The following is a description of a gene set: Human Gene Set: HUANG_GATA2_TARGETS_UP Genes up-regulated in G1ME cells (megakaryocyte/erythroid progenitor lacking GATA1) upon knockdown of GATA2 by RNAi. from publication Huang Z, Dore LC, Li Z, Orkin SH, Feng G, Lin S, Crispino JD (PMID 19620289) GATA-2 is an essential transcription factor that regulates multiple aspects of hematopoiesis. Dysregulation of GATA-2 is a hallmark of acute megakaryoblastic leukemia in children with Down syndrome, a malignancy that is defined by the combination of trisomy 21 and a GATA1 mutation. Here, we show that GATA-2 is required for normal megakaryocyte development as well as aberrant megakaryopoiesis in Gata1 mutant cells. Furthermore, we demonstrate that GATA-2 indirectly controls cell cycle progression in GATA-1-deficient megakaryocytes. Genome-wide microarray analysis and chromatin immunoprecipitation studies revealed that GATA-2 regulates a wide set of genes, including cell cycle regulators and megakaryocyte-specific genes. Surprisingly, GATA-2 also negatively regulates the expression of crucial myeloid transcription factors, such as Sfpi1 and Cebpa. In the absence of GATA-1, GATA-2 prevents induction of a latent myeloid gene expression program. Thus, GATA-2 contributes to cell cycle progression and the maintenance of megakaryocyte identity of GATA-1-deficient cells, including GATA-1s-expressing fetal megakaryocyte progenitors. Moreover, our data reveal that overexpression of GATA-2 facilitates aberrant megakaryopoiesis. studied in species Mus musculus, and this is the list of marker genes: LYZ, SAMSN1, GABARAPL1, MACROH2A1, IQGAP2, SH3KBP1, DEPP1, MNDA, RAB38, ARPC1A, PSMB8, FFAR2, CERK, GYG1, ST8SIA4, CLEC4E, HES6, CD244, MGST2, SLC2A6, C12orf57, MYL10, SIPA1L1, SPI1, LGALS1 (galectin 1), B2M, KIT, AFF1, ANKH, PRDX5, GCNT2, GPR171, COX6A1, FIS1, RIN3, DAP, MPO, IL17RA, LPXN, SFT2D2, ADSS1, ATP6V0E1, HLA-B, TESPA1, DOK3, CST3, CDKN1A, UBL5, UBA6, HHEX (NCBI Gene Id 5556), CCL15, MC5R, RNF130, FCGR2B, SAT1, SH3BGRL3, SQSTM1, STARD10, CDKN1B, ALOX5AP, RAB44, TOX, GREB1, ARID3A, GMFG, SLC12A6, SCAND1, TGIF1, MYL12B, SRGN, RHOG, TAPT1, P2RY14, LAT2 (NCBI Gene Id 7462), GLIPR1, EMP3, IFNGR2, KLK1, TXNIP, KCNN4, AP3S1, CLEC4D, TNFAIP8, TAP2, PLEC, PAX6, ACADM, TMEM50A, GPX1, RPS6, BTG1, IRAK3, CMTM7, TGFBR2, PIK3CG, IFITM1, FCGR2A, CCPG1, RAB31, GDPD3, GSN, CD93, BLOC1S1, CYTIP, TPCN1, TSPO, PSENEN, YPEL5, TP53INP1 (tumor protein p53 inducible nuclear protein 1), PLIN2, NEURL3, PSMB9, EVI2A, NDUFA6, NDRG1, AKR1B10, FUT8 (NCBI Gene Id 2530), PRORSD1P, ATP6V0D1, CD44, CTSE, ABTB1, GAB1, KCTD12, CPA3, C1orf54, FES, GSTO1, PLAC8, PRTN3, FAM117A, TNFAIP8L2, SLC8B1, DYNLT1, MYO1F, TYROBP, N4BP2L1, CALML4, ADGRG3 (NCBI Gene Id 58870), SATB1, SELPLG, NAPSA, HBP1, CEBPA, DGKG (diacylglycerol kinase gamma), HP, TGFBR1, GABARAP, ANXA2, FAM107B, IL16, CD47